Given this list of marker genes CALCRL, RAMP1, RAMP2, APP, CALCR, here is a description of the gene set: species: Homo sapiens Binding to a member of the calcitonin family (e.g. adrenomedullin, adrenomedullin 2 (intermedin), amylin, calcitonin and calcitonin gene-related peptides (CGRPs)). Human Gene Set: GOMF_CALCITONIN_FAMILY_BINDING